The following is a description of a gene set: electronically inferred by orthology from the curated human pathway Reactome Pathway: Tandem of pore domain in a weak inwardly rectifying K+ channels (TWIK) part of: Tandem pore domain potassium channels studied in species Mus musculus This event has been computationally inferred from an event that has been demonstrated in another species.<p>The inference is based on the homology mapping from PANTHER. Briefly, reactions for which all involved PhysicalEntities (in input, output and catalyst) have a mapped orthologue/paralogue (for complexes at least 75% of components must have a mapping) are inferred to the other species., and this is the list of marker genes: Kcnk6